The following is a description of a gene set: Genes positively differentially expressed in cell type: NK cell upon treatment with cytokine: M-CSF in mouse lymph nodes in vivo. Mouse Gene Set: CUI_NK_CELL_M_CSF_RESPONSE_UP from publication Cui A, Huang T, Li S, Ma A, Pérez JL, Sander C, Keskin DB, Wu CJ, Fraenkel E, Hacohen N (PMID 38057668) studied in species Mus musculus Cytokines mediate cell-cell communication in the immune system and represent important therapeutic targets. A myriad of studies have highlighted their central role in immune function, yet we lack a global view of the cellular responses of each immune cell type to each cytokine. To address this gap, the authors created the Immune Dictionary, a compendium of single-cell transcriptomic profiles of more than 17 immune cell types in response to each of 86 cytokines (>1,400 cytokine-cell type combinations) in mouse lymph nodes in vivo. A cytokine-centric view of the dictionary revealed that most cytokines induce highly cell-type-specific responses. For example, the inflammatory cytokine interleukin-1β induces distinct gene programmes in almost every cell type. A cell-type-centric view of the dictionary identified more than 66 cytokine-driven cellular polarization states across immune cell types, including previously uncharacterized states such as an interleukin-18-induced polyfunctional natural killer cell state., and this is the list of marker genes: Mrpl17, Ddx21, Tap2, B3gat3, Pfn1, Cep135